The following is a description of a gene set: studied in species Homo sapiens The presence of complexes of repetitive spikes and waves in EEG. Human Gene Set: HP_EEG_WITH_POLYSPIKE_WAVE_COMPLEXES EEG with polyspike wave complexes, and this is the list of marker genes: GABRG2, PIGY, APC2 (APC regulator of WNT signaling pathway 2), SLC25A1 (NCBI Gene Id 6576), PGAP2, PIGV, PGAP3, NEXMIF, CHD2, COL13A1, SLC18A3, MYO9A, GABRA1, JRK, ADGRG1, SYNGAP1, SPTAN1, SRPX2, PIGL, MTOR, SLC2A1, YEATS2, AP2M1, GABRD, VAMP1, YWHAG, CACNB4, SCN1A, PI4KA, PIGW, PIGO, SLC6A1, PRICKLE1, AKT3, SNAP25, SCARB2, PIK3CA, EFHC1, KCNC2, CILK1, SLC5A7, SETD1B, CLCN2, CHAT, CSTB, SYT2, PSAT1, AGRN, KCNQ3